The following is a description of a gene set: Cytokines mediate cell-cell communication in the immune system and represent important therapeutic targets. A myriad of studies have highlighted their central role in immune function, yet we lack a global view of the cellular responses of each immune cell type to each cytokine. To address this gap, the authors created the Immune Dictionary, a compendium of single-cell transcriptomic profiles of more than 17 immune cell types in response to each of 86 cytokines (>1,400 cytokine-cell type combinations) in mouse lymph nodes in vivo. A cytokine-centric view of the dictionary revealed that most cytokines induce highly cell-type-specific responses. For example, the inflammatory cytokine interleukin-1β induces distinct gene programmes in almost every cell type. A cell-type-centric view of the dictionary identified more than 66 cytokine-driven cellular polarization states across immune cell types, including previously uncharacterized states such as an interleukin-18-induced polyfunctional natural killer cell state. from publication Cui A, Huang T, Li S, Ma A, Pérez JL, Sander C, Keskin DB, Wu CJ, Fraenkel E, Hacohen N (PMID 38057668) studied in species Mus musculus Genes positively differentially expressed in cell type: pDC (plasmacytoid dendritic cell) upon treatment with cytokine: GM-CSF in mouse lymph nodes in vivo. Mouse Gene Set: CUI_PDC_GM_CSF_RESPONSE_UP, and this is the list of marker genes: Uhrf2, Pdia6, Psmb8, Taf7, Hmgcs1, Hsp90ab1, Msmo1, Gpatch4, Tubb4b (tubulin, beta 4B class IVB), Cct3, Pdap1, Ssr2, Cacybp, Hspa8, Nudt5, Basp1, Tma7, Hprt1, Spcs2, Calm1, Nars1, Aatf, Smc1a, Thyn1, Cfp, Rpn2, Fto, Sec61b (SEC61 translocon subunit beta), Ly6a, Hsbp1, Nme1, Eif5a, Gapdh, Vkorc1l1, Mrps15, Idi1, Gpx4, Tuba1b, Mdh2, Tap2, Atp5mc1, Dad1, Ly6d, Napsa (NCBI Gene Id 16541), Nt5c, Mydgf, Rbm17, Eloc, Tuba1a (tubulin, alpha 1A), Mea1, St13, Slc3a2, Gem, Calr, Pfn1, Akr1a1, Chmp2b, Grpel1, Fdps, Cfl1, Calm4, Stoml2, Dynll1, Hmgcr, Cited2, Tpi1, Cd74, Capg, Ldlr, Mrpl55, Btaf1, Ppa1, Mrps28, Gbp7